Given this list of marker genes TNFAIP3, TRAF6, SHARPIN, SLAMF1, TREM2, ITGA5, CD40LG, FANCD2, FANCA, TRAF5, ITGB1, TNIP2, RNF31 (ring finger protein 31), TRAF3IP2, CD40, TRAF2, here is a description of the gene set: studied in species Homo sapiens Human Gene Set: GOBP_CD40_SIGNALING_PATHWAY The series of molecular signals initiated by the binding of the cell surface receptor CD40 to one of its physiological ligands, and ending with the regulation of a downstream cellular process, e.g. transcription.